Given this list of marker genes WNT10A, LHX2, TSSK1B, ZNF385A, TRPC1, NACC1, OBSCN, PTK7, CABP7, KCNK12, CTSA, LRP8, PTMA, KCNQ4, ANGPTL2, USP49, SLC30A3, EIF2S1, C2CD2L, WDR53, DRD2, PTGES3, SOX5, NKX2-1, HOXA3, DLL4, IER5L, ATXN7L2, UBTF, BCL3, DGKG, UST, ETV4, TIGD6 (tigger transposable element derived 6), HNRNPL, JUND, SOX9, EDA, MAP1B, UBE2M, ARID1A, JUP, ASS1, PAK3, TSPAN33, RPIA, IGFBP7, SLC25A28, ARHGAP36, DPF3, HTR7, RELB, ATP5PD, HSPB2, ZNF362, RNF220, KITLG, LDB1, PTPRG, ATF5, RCOR2, KCNH8, APLP1, MECOM (MDS1 and EVI1 complex locus), DAB1, CREB3L1 (cAMP responsive element binding protein 3 like 1), SEMA6C, SIX4, GRIK3, GGNBP2, TEAD2, LHX6, SLC39A7 (solute carrier family 39 member 7), SLITRK5 (NCBI Gene Id 26050), TRIM28, E2F3, DSCAM, PLXNC1, IGF2BP1, DENND2D, CALM1, ERF, HIC1, SLC12A4, MLX, ZNF687, MFNG, CDK9, ZBTB7A, GNL1, L1CAM, FKBP14, NUFIP2, DSCAML1, SMAD7, BBS10, ZNF335, RASIP1, TMEM256, MKNK2, SOX10, CTCF, RIPOR1, ZFAND3, SCN5A, LIG3, EGLN2, CD83, LIN28A, TSPAN17, BARX1, UBA3, SCML2, CNP, WNK2, DTX3, DGCR2, NFIB, EIF3A, SPATA6, HPN, HOXA1, LRRC36, SP4, FAM76A, OTUD7B, MPC2, EFNB3, LCOR, ZNF593, CLDN7, CHRDL1, SRRM3, TSSK3, FGF11, ZNF703, HNRNPDL, HOXC10, PIP4K2B, P4HA1, KDM2A, CENPB, C6orf89, NOTCH3, PCIF1, HR, NFAT5, HIF1A, PABPC1, CIC, PKN1, GPBP1, ARHGAP30, KDM3B, MAFB, ROCK1, POU3F1, POU3F2, SPAG9, PRDM16, PITX2, BAG6, CEND1, MYCL, RFX6, CPEB4, FRMPD1, PPM1E, NR3C1, CDC14A, SIX1, PDGFB, FBXO34, ZNF281, THAP11, LMO4, RXRB, CNKSR1, TLK2, FLT3LG, ZNRF2, NEO1, SMG1, PLEKHA8, NXPH4 (NCBI Gene Id 11247), SOS1, PABPC4, MAP3K11, SIPA1, CERCAM, CTDNEP1, KLF13, FER1L6-AS1, MXD4, TRERF1, PDLIM2, TRMT1, IL11, IRAG1, ATP6V1D, KCNJ12, CDC73, CDON, ARPC4, UBE2H, CBX6, ADGRL3, NFATC3, CRYAB, NUP62, MYH7, PLP2, MARCKSL1 (MARCKS like 1), STAT3, PHC2, NIBAN1, PRR3, GMIP, CXXC5, MAP3K6, CIB1 (calcium and integrin binding 1), ANKRD2, MSTN, GPRC5C, MED13, JOSD2, TKFC, MAN1C1, KLF12, GRHL2, APLP2, YTHDF2, CCDC24, GAS7, FKRP, SLC6A11, MAP2K2, RARG, KRT4, FBRS, ARTN, NR2C2, CMTR1 (NCBI Gene Id 23070), NYAP1, SPACA6, KAT5, ELP5, KLF10, JARID2, IL4I1, FCRLA, TMEM131L, here is a description of the gene set: Human Gene Set: AP2GAMMA_01 species: Homo sapiens Genes having at least one occurrence of the motif GCCYNNGGS in the regions spanning 4 kb centered on their transcription starting sites. This matches the TFAP2C transcription factor binding site V$AP2GAMMA_01 (v7.4 TRANSFAC).